Given this list of marker genes Dpm1, Upf3b, Sppl3, Actn4, Clk1 (NCBI Gene Id 98487), Ythdc1, H2az2, Slc4a5, Ing1, Kif5b, Pnn, Osbpl11, Mpv17, Otud5, Kat2b, Aplp2, Wwc2, Eloc (elongin C), Scarb2, Htra1, Pias2, Chi3l1, Antxr2, Ogn, Klf13, Wdr81, Zfp131, Mindy1, Tia1, 4833420G17Rik, Kmt2a, Tmco1, Glg1, Etnk1, Dnajc10, Pias1, Arhgap21, Pgrmc1, Yipf5, Hnrnph1, Pld1, Clock, Jkamp (JNK1/MAPK8-associated membrane protein), Eif3m, Sirpa, Ank3, Pdgfa, C1qtnf3, Zscan26, Smo, Ift20, Srsf1, Rell1, Gtf2e2, Ptprs, Vps26b, Sf3b1, Tprg1l, Vps4a, Apbb2, Nrip1, Ctcf, Thra, Ptgs1, Zfp639, Arpc3, Zfp932, Lims1 (NCBI Gene Id 71899), Ifnar2, Atxn2, Ptprd, Prpsap2, Ephb6, Ddc, Itih4, Rnf6, Gfra2 (NCBI Gene Id 14586), Nras, Mef2d, Cast, Mdm4, Rnf149, Paip2, Mtch1, Ext1, Rcn1, Chd8, Mocs2, Fxn, Mapk1, Stx3, Hnrnpc, Kdr, Eif1ax, Ccnl2, Prmt1, Serpina10 (serine (or cysteine) peptidase inhibitor, clade A (alpha-1 antiproteinase, antitrypsin), member 10), Wdr48, Med23, Smad4, 1600012H06Rik, Parp6, Rrp1b, Tm7sf3, Tug1, Tnpo2, Ireb2, 2510002D24Rik, Cggbp1 (NCBI Gene Id 224295), Cadm1, Agpat5, Slc22a23, Lats2 (large tumor suppressor 2), Wdr26, Nfib, Ginm1, Slc35a1, Pkd2 (polycystin 2, transient receptor potential cation channel), Pja1, Tpst1, Ube2v2 (NCBI Gene Id 98028), Mthfr, Mrps34, Stxbp3, Ddx3x, Zfp871, Cd200, Rasa1 (RAS p21 protein activator 1), here is a description of the gene set: Mouse Gene Set: STEARMAN_LUNG_CANCER_EARLY_VS_LATE_UP from publication Stearman RS, Dwyer-Nield L, Grady MC, Malkinson AM, Geraci MW (PMID 18172294) One area of intensive investigation is to understand complex cellular and signaling interactions in the tumor microenvironment. Using a novel, although straightforward, microarray approach, we defined a gene expression signature from the lung tumor microenvironment in the murine A/J-urethane model of human lung adenocarcinoma. The tumor microenvironment is reflected by the composition of the cell types present and alterations in mRNA levels, resulting in a Field Effect around the tumor. The genes composing the Field Effect expression signature include proteases and their inhibitors, inflammation markers, and immune signaling molecules. By several criteria, the Field Effect expression signature can be attributed to the macrophage lineage, suggesting a qualitative change in the expression pattern of tumor-associated macrophages (TAM) observed in lung tumors. The protein expression levels for a number of Field Effect genes were verified by Western blot analysis of lung homogenates, and for their expression in macrophages and parenchymal cells outside of the tumors by immunohistochemistry. In addition, the Field Effect expression signature was used to classify bronchoalveolar lavage (BAL) cells from tumor-bearing or age-matched control mice. Using a variety of statistical measures, the Field Effect expression signature correctly classified the BAL cells >94% of the time. Finally, the protein levels for several Field Effect genes were higher in cell-free BAL fluid, indicating they may be secreted by the TAMs. This work suggests that TAMs generate a unique gene expression signature within the tumor microenvironment, and this signature could potentially be used for identifying lung cancer from BAL cells and/or fluid. species: Mus musculus Up-regulated genes classifying non-tumor lung tissues by age after incution of lung cancer by urethane injection: early (24-26 weeks) vs late (46 weeks).